Given this list of marker genes Map3k7, Chuk, Cd40, Erbin (NCBI Gene Id 72261), Ephb2, Mapk8, Rela, Ikbkg, Ikbkb, here is a description of the gene set: studied in species Mus musculus Mouse Gene Set: WP_NODLIKE_RECEPTOR_NLR_SIGNALING_PATHWAY Nod-like receptor (NLR) signaling pathway